The following is a description of a gene set: Mouse Gene Set: CUI_MONOCYTE_IL36A_RESPONSE_UP Genes positively differentially expressed in cell type: Monocyte upon treatment with cytokine: IL-36α in mouse lymph nodes in vivo. Cytokines mediate cell-cell communication in the immune system and represent important therapeutic targets. A myriad of studies have highlighted their central role in immune function, yet we lack a global view of the cellular responses of each immune cell type to each cytokine. To address this gap, the authors created the Immune Dictionary, a compendium of single-cell transcriptomic profiles of more than 17 immune cell types in response to each of 86 cytokines (>1,400 cytokine-cell type combinations) in mouse lymph nodes in vivo. A cytokine-centric view of the dictionary revealed that most cytokines induce highly cell-type-specific responses. For example, the inflammatory cytokine interleukin-1β induces distinct gene programmes in almost every cell type. A cell-type-centric view of the dictionary identified more than 66 cytokine-driven cellular polarization states across immune cell types, including previously uncharacterized states such as an interleukin-18-induced polyfunctional natural killer cell state. studied in species Mus musculus from publication Cui A, Huang T, Li S, Ma A, Pérez JL, Sander C, Keskin DB, Wu CJ, Fraenkel E, Hacohen N (PMID 38057668), and this is the list of marker genes: Tpm3, Clec4n, Actg1, Llph (NCBI Gene Id 66225), Vti1b, BC031181, App, Wapl, Mrpl52, Srsf3, Siglece, Bcl2a1b, Rbms1, Slc2a1, Stk19, Dnajb11, Eif4a1, Slfn1, Arl1, Fth1, Vcan, Eif3a, Sdc4, Socs3, Ifitm2, Ciao2b, Upp1, Vim, Ccl24, Pkm, Ldha, Cux1, Vapa (vesicle-associated membrane protein, associated protein A), Tle3, Nrg1, Ms4a4c, Eps8, Rap2c, Irf2bp2, Fcgr3, Slc7a11, Ltb4r1, Mafb, Mydgf, Tspo (translocator protein), Cfl1, Card19, Carhsp1, Il1rn, Nab1, Dmkn (dermokine), Tfec, Atp11a, Ifi204, Irgm1, St6galnac4, Cndp2, Bcl2a1d, Naa25, Marcks, Ctsl, Plek, Pfn1, Kdm6b, Rigi, Plaur, Ilrun, Slfn5, Mxd1, Il4ra, Atp5mc1, C3ar1, G3bp1, Hsd17b12, Manf, Pet100, Atp1a1, Slpi, Arhgap31, Skap2, Eea1, Srgn (serglycin), Eif2s1, Ifi47, Psmb4, Gbp9, Ninj1, Cd44, Tgfbi (transforming growth factor, beta induced), Spred1, Acod1, Hnrnpu (NCBI Gene Id 98724), Chil3, Tgm2, Trim30c, Adam8, Capza2, Sarnp, Ccl2, Stxbp3 (NCBI Gene Id 20912), Rbpj, Rab44, Rrbp1, Runx1, Hax1, Cstb, Clec4d, Calr (calreticulin), Eif5a, Tpm4 (tropomyosin 4), Eif4g2, Snx18, C5ar1 (complement component 5a receptor 1), Arf1, Ostc, Dok2, Cmklr1, Cd14, Azin1, Snx2, Slfn2, Sec61g, Ifitm1, Rnasel, Cd164, Ranbp2, Smox, Ssr3, Gsr, Tarm1, Ube2d3, Hnrnpm (NCBI Gene Id 76936), Daxx, Pdia6, Srsf2, Fcgr1, Nampt, Nus1, Tmed2, Ctsz, Cycs, Ap3s1, Slc15a3, Hspa5, Ifi207, Ggct, Arhgap26, F10, Il1b, Etf1, Riok3, Marcksl1, Cd274, Dram1, Stt3b, Igtp, Magohb, Nme1, Kras, Ms4a6d, Cfp, Thbs1, Cltc, Slc35b1, Emilin2, Bst1, Casp4, Cd40, Gbp7, Gda, Tap1, Uck2, Itgam, Erh, Pnp, Irgm2, Psmd14, N4bp1, Dab2, Eif2s3x, Lrrc59, Tpd52, Pdia4, Hsp90b1 (heat shock protein 90, beta (Grp94), member 1), Ifi209, Heatr1, St3gal1, Mapk6, Cd300lf, Cox17, Cggbp1, Map2k3, Ppa1 (NCBI Gene Id 67895), Isg15, Ppp6c, Lcp2, Clic4 (chloride intracellular channel 4), Ehd1, Stx11, Cxcl10, Cd53, Sys1, Sod2, Bcl2a1a, Srsf7, Mt1 (NCBI Gene Id 17748), Ptafr, Eif1, Txn1, Hnrnph2, Rgl1, Scimp, Mmp14, Lilrb4b, Ccr5, Psmb6 (NCBI Gene Id 19175), Gch1, Creld2, Bak1, Ikbke, Slc39a7, Parp14, Casp6, Kdelr2, Adprh, Ppp4r2, Msr1, Lcn2, Maf, Clec4e, Ssr2, Ccl12, Agfg1, Fpr2, Hif1a, Ifi205, Dnaja2, Ell2, Hnrnpab, Fcer1g, Sdcbp, Spcs2, Hnrnpa3 (heterogeneous nuclear ribonucleoprotein A3), Myl12a, Litaf, Pilra, Lpxn, Itsn2, Rybp, Trim30a, Morf4l2, Ssr1, Ccr1, Fabp5, Rab8b, Il1rap, Tor1aip1, Ifi211, BC005537, Niban2, Krtcap2, Sar1a, Ctsc, Txnrd1, Srm, Tes, Selenos, Glrx, Rab20, Cdkn1a